Given this list of marker genes Bmp6, Bmp2, Dgkq, Dab2, Pde8b, Wnt4, Igf2, Dkk3, Atp1a1, Bmp5, Cyp17a1, Nr3c1, Gh, Igf1, Nr5a2, Lhcgr, H6pd, Rest, Igf1r, Por, Clcn2, here is a description of the gene set: Mouse Gene Set: GOBP_REGULATION_OF_STEROID_HORMONE_BIOSYNTHETIC_PROCESS species: Mus musculus Any process that modulates the frequency, rate or extent of the chemical reactions and pathways resulting in the formation of steroid hormones,compounds with a 1, 2, cyclopentanoperhydrophenanthrene nucleus that act as hormones.